The following is a description of a gene set: Genes up-regulated in MCF7 cells (breast cancer, normal TP53) undergoing aberrant mitosis and necrosis after treatment wiht 4 nM docetaxel. Human Gene Set: HERNANDEZ_ABERRANT_MITOSIS_BY_DOCETACEL_4NM_UP from publication Hernández-Vargas H, Palacios J, Moreno-Bueno G (PMID 17099726) species: Homo sapiens Among microtubule-targeting agents, docetaxel has received recent interest owing to its good therapeutic index. Clinical trials have underlined its potential for the treatment of advanced breast cancer, although little is known about its molecular mode of action in this context. We characterized the molecular changes induced by docetaxel in two well-known human breast carcinoma cell lines. Two mechanisms of action according to drug concentration were suggested by a biphasic sensitivity curve, and were further validated by cell morphology, cell cycle and cell death changes. Two to four nanomolar docetaxel induced aberrant mitosis followed by late necrosis, and 100 nM docetaxel induced mitotic arrest followed by apoptosis. Passing through mitosis phase was a requirement for hypodiploidy to occur, as shown by functional studies in synchronized cells and by combining docetaxel with the proteasome inhibitor MG132. Transcriptional profiling showed differences according to cell line and docetaxel concentration, with cell cycle, cell death and structural genes commonly regulated in both cell lines. Although p53 targets were mainly induced with low concentration of drug in MCF7 cells, its relevance in the dual mechanism of docetaxel cytotoxicity was ruled out by using an isogenic shp53 cell line. Many of the genes shown in this study may contribute to the dual mechanism by which docetaxel inhibits the growth of breast cancer cells at different concentrations. These findings provide a basis for rationally enhancing docetaxel therapy, considering lower concentrations, and better drug combinations., and this is the list of marker genes: CD53, MITF, PMEL, TNFRSF11B, GAGE12F, TIMP3, CDKN1A, MAGEA6, GHR, GEM, SGK1, NT5E, MAGEA12, MAF, TP53INP1, HLF, PRAME, RASGRP1, FGG, POSTN, H2BC21, CERKL, TYRP1